The following is a description of a gene set: studied in species Mus musculus Mouse Gene Set: GOBP_MALE_SEX_DETERMINATION The specification of male sex of an individual organism., and this is the list of marker genes: Sox9, Map3k4, Ptgdr, Fgf9, Dmrt1, Igf1r, Ar, Nr5a1, Dhh, Sry, Gnrh1 (NCBI Gene Id 239161), Insrr, Nr0b1, Six4, Insr, Sf1